The following is a description of a gene set: Genes down-regulated in comparison of dendritic cells (DC) stimulated with poly(I:C) (TLR3 agonist) at 24 h versus DC cells stimulated with Pam3Csk4 (TLR1/2 agonist) at 24 h. from publication Amit I, Garber M, Chevrier N, Leite AP, Donner Y, Eisenhaure T, Guttman M, Grenier JK, Li W, Zuk O, Schubert LA, Birditt B, Shay T, Goren A, Zhang X, Smith Z, Deering R, McDonald RC, Cabili M, Bernstein BE, Rinn JL, Meissner A, Root DE, Hacohen N, Regev A (PMID 19729616) mouse primary BMDCs were stimulated with tlr ligands and gene expression changes were profiled on Affymetrix arrays studied in species Homo sapiens Human Gene Set: GSE17721_POLYIC_VS_PAM3CSK4_24H_BMDC_DN, and this is the list of marker genes: KLHL7, RPL7L1, STMN1, GRHPR, DDHD2, RPS15A, WBP2, SRP19, PRXL2B, CP, PLCB4, ARL1, DHPS, CDC25A, IL1RAP, LPCAT1, PREB, SMIM30, UNG, SLCO3A1, HCST, GSTM3, EIF5A, ARMT1, IL16, YWHAG, DGAT1, LDB2, TFB2M, ANKH, LRRC3B, MRPL11, IPO9, YIPF4, MRPL45, CDK4, ADAM17, SPN, NAB2, SDHC, B3GALNT1, RND3, SWI5, PRIM2, MRAS (muscle RAS oncogene homolog), IMPDH2, PNKP, MBOAT7, MRRF, NNT, DERL2, PIM3, ADAM9, UQCRFS1, RIOX2, DNAJB6, CHURC1, UGGT1, CARMIL1, LRRC59, KIF2A, MAD2L1, VCAN, S100A1, SPRYD7, PUM3, OTOG, SRP14, CRTAP, ACADVL, UBE2G2, METRN, CCDC107, SNX18, SNRNP25, APPBP2, LRRC49, ALPK3, HCLS1, SEC61B, PTGES, TRAM1 (NCBI Gene Id 23471), TMEM134, VIP, SMC3, MRPL48, MSANTD3, PRMT3, E2F3, MOB4, TAF9, ACTR6, SLC19A1, ZMPSTE24, SEM1, ARMH4, PIGK (phosphatidylinositol glycan anchor biosynthesis class K), ITGAX, NUP160, ENPP2, LSS, ALDOA, RPL37A, TEX2, MYEF2, ANXA6, CALCRL, BET1, COPS6, HERC2, NCBP1, RABAC1, FMC1, IGFBP4, EPCIP, LAGE3, PIK3CA, PPP1R14B, NPM1, HBS1L, SREBF2, CHAC2, DIS3, SERBP1, ADSS2, TXLNB, IMP4, MAP2K6, ERRFI1, MFSD1, DYNLT3, MAD2L2, MAFF, NDUFB10, GNG2, RNF128, PMPCA, ELOVL1, CLPB, TCEAL9, WLS, DNAJC18, RNF19A, NDUFV2, PIP, ATP5MC3, DARS1, INSM1, PBXIP1, BHLHE40, DDB1, EIF4E, PPP2R3C, MCUB, BTF3L4, TAL2, OTUD6B, MCM3, NDUFB2, HECTD1, PTPMT1, PRRC1, CAPZA1, GSS, DACH1, WBP11, CEP55, GMFG, PRKCI, CAD, MFSD14A, UBE2C, DLST (dihydrolipoamide S-succinyltransferase), ABHD17A, SLAIN2, BRAF, RAB34, HSP90B1, GBE1 (NCBI Gene Id 2632), RPL27A, BLVRA, GK, NDUFA3, CCT4, CNPY2, C11orf24, CDK1, SLC30A6, FCHO1, AZIN1, CERS5, FAM174A, ESYT3, FTSJ3, SLC1A2, HM13, NCF1, TMEM97, SSBP4